The following is a description of a gene set: species: Homo sapiens Human Gene Set: REACTOME_REGULATION_OF_TLR_BY_ENDOGENOUS_LIGAND Regulation of TLR by endogenous ligand, and this is the list of marker genes: TLR4, S100A9, FGG, CD14, CD36, GSDME, APOB, HMGB1, LBP, GSDMD, TLR1, S100A1 (NCBI Gene Id 6271), TLR7, TLR2, LY96, SFTPA1, SFTPA2, TLR6, S100A8, FGB, FGA, SFTPD